Given this list of marker genes AKT3, MITF, MC1R (melanocortin 1 receptor), CREB1, MC4R, ID1, CSF1, EDNRB, XPO1, MAPK3, EDN3, RPS6KA1, SOX9, QARS1, MARK3, SOX2, HDAC1, IARS1, SIRT1, TNFSF11, MC5R, HINT1 (histidine triad nucleotide binding protein 1), AIMP2, AIMP1, GSK3B, CDH1, POU3F2, RARS1, KIT, SNAI2, LEF1, KARS1, YWHAE, YWHAB, YWHAG, UBE2I, CTNNB1, YWHAH, POMC, MAPK1, SOX10, YWHAZ, FOXD3, LARS1, TFEC, EDN1, EP300, TBX3, ALX3, EEF1E1, TFE3, TFEB, EPRS1, MARS1, PAX3, SUMO1, DARS1, KITLG, MC3R, ZIC1, CREBBP, WNT3A, here is a description of the gene set: species: Homo sapiens Reactome Pathway: Transcriptional and post-translational regulation of MITF-M expression and activity part of: MITF-M-regulated melanocyte development Melanocytes, neurons and glia all arise from precursor cells derived from neural crest cells. Cells that will give rise to neurons and glia migrate away from the neural crest earlier and in a ventral pattern, while cells that will give rise to melanocytes leave the neural crest later and migrate dorsolaterally. Nevertheless, melanocytes can also arise in an alternate pathway from dual Schwann cell/melanocyte precursors or by dedifferentiation from Schwann cells, a derivative of the glial lineage. MITF-M is a key regulator of melanocyte development, and its expression distinguishes the melanocyte fate from that of glial and neural cells. MITF-M expression is repressed in precursors through the activity of FOXD3 and SOX2. Depending on the species, these transcription factors may either bind directly to elements in the MITF-M promoter to repress transcription, or may act independently of DNA binding by disrupting protein-protein interactions that promote transcriptional activity. FOXD3 and SOX2 expression, in turn, are regulated by a cascade of other transcription factors, including ZIC1, PAX3, SNAIL2 and SOX9. <br>Relief of FOXD3 mediated repression may depend in part on HDAC1, as well as on down regulation of SNAIL2. MITF-M expression in unpigmented but committed melanoblasts depends on PAX3 and SOX10 binding at the promoter as well as on WNT, EDNRB and KIT signaling. Initial expression of MITF-M also contributes to downregulation of FOXD3 and SOX2 establishing a positive feedback loop that reinforces commitment to the melanocyte fate.<br>In addition to transcriptional regulation, MITF-M activity is also controlled by post translational modifications, although the significance of these modifications is not always clear. SUMOylation, ubiquitination and phosphorylation downstream of MAPK, WNT and AKT signaling can all impact the stability, localization or activity of MITF-M, and acetylation regulates the occupancy of target promoters, decreasing occupancy at differentiation-specific promoters. <br>